Given this list of marker genes STAT3, TSC22D1, C1QB, ATP5MC1, AMD1, EBP, ATP2A2, CD68, SERPINB1, FCER1G, CSRP2, GTF3A, PPP2R5C, BOLA2, TUBA3C, F13A1, PTDSS1, ISG15, SLC31A2, IFITM2, PQBP1, TUBA3E, DAAM1, IFNGR1, RAB9A, NQO2, SERPINA3, MYH6, IFITM3, IFITM1, NME2, VAT1, ABCB6 (NCBI Gene Id 541461), CD14, FCN3, WARS1, ZP3, IRAK1, LPCAT4, PSME2, SLC39A14 (solute carrier family 39 member 14), TMEM147, LDHA, DEXI, here is a description of the gene set: Human Gene Set: KAAB_FAILED_HEART_VENTRICLE_DN To obtain region- and disease-specific transcription profiles of human myocardial tissue, we explored mRNA expression from all four chambers of eight explanted failing, and five non-failing hearts using high-density oligonucleotide arrays (Affymetrix U95Av2). We performed pair-wise comparisons of gene expression in the categories (1) atria versus ventricles, (2) disease-regulated genes in atria and (3) disease-regulated genes in ventricles. In the 51 heart samples examined, genes showed divergent distribution between atria and ventricles (genes with higher expression in atria, genes with higher expression in ventricles). Two hundred and eighty-eight genes were differentially expressed in failing myocardium compared to non-failing hearts (genes regulated in atria and ventricles, 172 regulated in atria only, genes regulated in ventricles only). For disease-regulated genes, down-regulation was 4.5-times more common than up-regulation. Functional classification according to Gene Ontology identified specific biological patterns for differentially expressed genes. Eleven genes were validated by RT-PCR showing a good correlation with the microarray data. Our goal was to determine a gene expression fingerprint of the heart, accounting for region- and disease-specific aspects. Recognizing common gene expression patterns in heart failure will significantly contribute to the understanding of heart failure and may eventually lead to the development of pathway-specific therapies. from publication Kääb S, Barth AS, Margerie D, Dugas M, Gebauer M, Zwermann L, Merk S, Pfeufer A, Steinmeyer K, Bleich M, Kreuzer E, Steinbeck G, Näbauer M (PMID 15103417) Genes down-regulated in the ventricles of failing hearts (DCM and ICM) compared to the healthy controls. species: Homo sapiens